The following is a description of a gene set: Human Gene Set: WP_REGULATION_OF_SISTER_CHROMATID_SEPARATION_AT_THE_METAPHASEANAPHASE_TRANSITION species: Homo sapiens Regulation of sister chromatid separation at the metaphase-anaphase transition, and this is the list of marker genes: STAG1, BUB1, BUB1B, CDC20, SMC1A, RAD21, MAD2L1, ESPL1, APC, PTTG1, MAD1L1, SMC3, BUB3 (BUB3 mitotic checkpoint protein), CENPE